Given this list of marker genes SLC2A1, SCN1A, DMPK, GJA8, PQBP1, CNBP, NEXMIF, ABCD1, ALMS1 (ALMS1 centrosome and basal body associated protein), SLC6A1, AP2M1, RNU4-2 (RNA, U4 small nuclear 2), CHD2 (chromodomain helicase DNA binding protein 2), SYNGAP1, NR3C1, WNT4, GJA5, here is a description of the gene set: Absence of hair in the anterior midline and/or parietal areas. Frontal balding species: Homo sapiens Human Gene Set: HP_FRONTAL_BALDING